Given this list of marker genes Lgals9 (lectin, galactose binding, soluble 9), Cdk5, Itgb7, Rac1, Flna, Grik5, Thy1, Itgb2, Lrp5, Pigr, Madcam1, Grip2, Glrb, Magi2 (NCBI Gene Id 50791), Pick1, Gsn, Zdhhc2, Musk, Grik2, Dlg2, Mesd, Itga4, Tnfaip6, Slc7a11, Chrdl1, Scrib, Dvl1 (NCBI Gene Id 13542), Nlgn2, Akap5, Itgb2l, Fzd9, Ssna1, Crkl, Sorbs1, Gphn, Dlg4 (discs large MAGUK scaffold protein 4), Reln, Apoe (NCBI Gene Id 11816), Ift122, Nrxn2, Itgal, Nrxn1, Ptn, Lrrc7, Cd53, Lrrtm4 (leucine rich repeat transmembrane neuronal 4), Rer1, Shisa7, Agrn, Grin2b, Clec2i (NCBI Gene Id 93675), Slitrk3, Gripap1, Shisa6, Shank3, Arhgef9, Fnta, Sorbs2, Nlgn1 (neuroligin 1), Syngap1, Dok7, Cdh2, Colq, Dlg1, Dnaja3 (DnaJ heat shock protein family (Hsp40) member A3), Snx27, Nme7, Farp1, Cacna1a, Pak1, Crk, Cd81, Itgb1bp1, Ssh1, Lhfpl4, Htr1a, Etv5, Wdr19 (WD repeat domain 19), Rapsn, Frrs1l, Dlg3, Lrp4, here is a description of the gene set: studied in species Mus musculus Mouse Gene Set: GOBP_RECEPTOR_CLUSTERING The receptor metabolic process that results in grouping of a set of receptors at a cellular location, often to amplify the sensitivity of a signaling response.